The following is a description of a gene set: Mouse Gene Set: TERAMOTO_OPN_TARGETS_CLUSTER_6 Cluster 6: genes exhibiting prolonged up-regulation (>72 h) after knockdown of OPN by RNAi in the NIH3T3 cells (fibroblasts) transformed by activated HRAS. studied in species Mus musculus Activated forms of Ras family members are prevalent in many cancers where Ras mutants transduce signals essential for transformation, angiogenesis, invasion and metastasis. As a cancer progression model, we used NIH3T3 cells to explore the mechanism of Ras-induced tumorigenesis. Ras family mutants H-RasV12 and Rit79L strongly induced foci formation, while Rho family mutants RhoA-QL, Rac1-QL and Cdc42-QL were less effective. A comparison of downstream transcriptional targets of Ras and Rho family members using a 26 383 element cDNA microarray revealed that the osteopontin (OPN) gene exhibited the best correlation between magnitude of gene expression change and level of foci formation (r=0.96, P<0.001). In association with H-RasV12- and Rit79L-mediated transformation, foci secreted OPN protein and upregulated the OPN receptor CD44, suggesting the novel initiation of an aberrant OPN-CD44-Rac autocrine pathway. In support of this were the following observations. First, RGD-deficient OPN protein-binding activity was present in H-RasV12-transformed cells but not in control cells, and binding activity was inhibited by the CD44 blocking antibody. Second, foci formation, cell invasion and Rac activity were induced by H-RasV12 and inhibited by the CD44 blocking antibody. Third, foci formation by H-RasV12 was substantially reduced by a short interfering RNA (siRNA) specifically targeting OPN expression for knockdown. Fourth, H-RasV12-mediated transformation was not blocked by the GRGDS peptide, suggesting that OPN effects were not mediated by the integrins. Lastly, OPN knockdown affected the downstream expression of 160 '2nd tier' genes, and at least a subset of these genes appears to be involved in transformation. Indeed, four genes were selected for knockdown, each resulting in a disruption of foci formation and/or invasion. These results underscore the role of aberrant autocrine signaling and transcriptional networking during tumorigenesis. from publication Teramoto H, Castellone MD, Malek RL, Letwin N, Frank B, Gutkind JS, Lee NH (PMID 15516973), and this is the list of marker genes: Slit1 (NCBI Gene Id 226119), Elmo2, Ndrg2, Pdgfrb, Ppp5c, Tmem107, Kctd20, Actn4, Sparcl1, Apod, Bloc1s1, Pih1d1, Psme1, Adamts7, Ccdc3, Gfus, Olfml3, Tspan9, Mmp7, Acacb, Serpinf1, Zdhhc2, Ccdc80, Soat1, Rita1, Dand5